Given this list of marker genes HAUS7, HAUS4, HAUS6, HAUS2, HAUS5, HAUS3, HAUS8, HAUS1, here is a description of the gene set: Human Gene Set: GOCC_HAUS_COMPLEX species: Homo sapiens A protein complex that localizes to interphase centrosomes and to mitotic spindle tubules and regulates mitotic spindle assembly and centrosome integrity; in human, the complex consists of eight subunits, some of which are homologous to subunits of the Drosophila Augmin complex.